Given this list of marker genes USP15, SUPT6H, EPOP, SUPT4H1, CDK9, SUPT5H (NCBI Gene Id 6829), SART3, GLYR1, IWS1, here is a description of the gene set: studied in species Homo sapiens A chromatin remodeling process that reestablishes the chromatin structure following the passage of RNA polymerase II during transcription elongation, thus preventing cryptic transcription initiation. Human Gene Set: GOBP_TRANSCRIPTION_ELONGATION_COUPLED_CHROMATIN_REMODELING